Given this list of marker genes PITPNC1, TRIM71, MAN2A1, SERPINE1, IREB2, MAGI1, REL, CYB5B, FOXD3, CFAP44, ZNF619, NLGN1, STK32A, ATF7IP, CDC20B, XPNPEP3, ZNF490, LGSN, RAB11FIP1, NLK, PGAP6, ULK3, GPT2, UROS, LRRTM2, EXOG, AZIN1 (antizyme inhibitor 1), SMARCAD1, DYNC1LI2 (dynein cytoplasmic 1 light intermediate chain 2), CELF3, MACROH2A2, MEAF6, ACVR2B, PTGFRN, MAN2B2, DIS3L2 (NCBI Gene Id 282696), DCTN2, EIF4A3, TSC22D2, MSN, PFN1, MLC1, ABHD18, KATNBL1, RBPJ, RPS29, LRG1, AXIN2, COBL, CCDC172, MITF, SUDS3, EIF2S3, SSBP3, TMX4, TMED7, POGLUT1, YBX1, GOSR1, CREBRF, NFAT5, FAM169A, TM9SF1, ZZEF1, VSTM2A, PPP1R14B, ATP8A2, TIMP3, URB2, PANK1, DMRT1, PROX2, WNK1 (WNK lysine deficient protein kinase 1), SPATA2, TNKS2, POLR2D, MELTF, BBIP1, ACSL1, PIK3R3, PNOC (prepronociceptin), ZC3H12C, PAK2, HSPB7, STRN3, UQCC6, ZNF880, MTA3, SEMA5A, SLC7A5, DDN, FCHSD2, PFDN4, FBXL20, CD81, SYT14, here is a description of the gene set: from publication Chen Y, Wang X (PMID 31504780) Human Gene Set: MIR6771_3P Genes predicted to be targets of miRBase v22 microRNA hsa-miR-6771-3p in miRDB v6.0 with MirTarget v4 prediction scores > 80 (high confidence targets). studied in species Homo sapiens